The following is a description of a gene set: part of: Cytochrome P450 - arranged by substrate type A number of CYPs take part in cholesterol biosynthesis and elimination, thus playing an important role in maintaining cholesterol homeostasis. Under normal physiological conditions, cholesterol intake (diet or synthesized de novo from acetyl CoA) equals cholesterol elimination (degraded to bile salts, secreted in bile and used in steroid hormone synthesis). These processes are under tight regulatory control and any disruption leads to increased cholesterol levels resulting in cardiovacular disease. The CYPs involved in cholesterol homeostasis could serve as potential targets for cholesterol-lowering drugs. species: Homo sapiens Reactome Pathway: Endogenous sterols, and this is the list of marker genes: NR1H4, RXRA, CYP27A1, CYP39A1, ARNT, CYP51A1, AHR, CYP7A1, AHRR, CYP11B2, CYP11B1, CYP11A1 (cytochrome P450 family 11 subfamily A member 1), CYP19A1, CYP21A2, FDXR, FDX2, CYP8B1, FDX1, CYP7B1, CYP1B1, ARNT2, NCOA1, NCOA2, CYP46A1, POMC, CYP4V2